Given this list of marker genes BCL10, TNFSF13B, TRAF3IP2, BAX, BCL2L11, CD74, MIR17HG, HIF1A, DOCK10, PKN1, ADA, NCKAP1L, BCL2, IKBKG, SOS1, PPP2R3C, LYN, CAMLG, TNFAIP3, GAPT, BBIP1 (BBSome interacting protein 1), SH2B2, RC3H2, RC3H1, ABL1, MIF, DOCK11, CASP3, BAK1, MEF2C, IL7R, SPNS2, TNFRSF13B, BBS4, SASH3, SOS2, FOXP3, here is a description of the gene set: studied in species Homo sapiens Human Gene Set: GOBP_B_CELL_HOMEOSTASIS The process of regulating the proliferation and elimination of B cells such that the total number of B cells within a whole or part of an organism is stable over time in the absence of an outside stimulus.